The following is a description of a gene set: Genes containing one or more binding sites for (ZNF768) in their promoter regions (TSS -1000,+100 bp) as identified by GTRD version 20.06 ChIP-seq harmonization. from publication Yevshin I, Sharipov R, Kolmykov S, Kondrakhin Y, Kolpakov F (PMID 30445619) Human Gene Set: ZNF768_TARGET_GENES species: Homo sapiens, and this is the list of marker genes: RAP1GAP, REV3L, TXNIP, SSBP1, ZSWIM3, TBC1D22A, PRRG2, RPS27P8, VPS13B, SPAG5, OPA3, RNU5E-4P, ALPL, CEP112 (centrosomal protein 112), CERCAM, MIR4519, SFTA2, KRBA1, OR6S1, MLLT10P2, PVRIG, WDR11, DGAT2, ZNF131, CAP1, ECI2-DT, UBE2Q2P1, SLC8B1, DKFZP434A062, OCIAD1, PPP2R2A, SP110, XYLT1, WSCD1 (WSC domain containing 1), UBE2A, TIGD6, RBPMS2, SELL, MCCC1, SIGLEC14, NSMAF, ATF7IP, IFI16, STMP1, CCDC85C, STIM2, SP140, PLA2G6, ZNF324B, SIRT7, MIR6881, RIPOR2, GDPD5, HOXA11-AS (NCBI Gene Id 221883), CARD10, DOC2GP, TMEM63B, SMPD4, PSMB10, OAS2 (NCBI Gene Id 4939), ELK4, PRR5, ZMPSTE24-DT, KLK10, ETHE1, FZD4 (frizzled class receptor 4), WSCD2, DISP1, TIMM29, RBM47, H2BC16P, SMAGP, CHD1L, SLC1A6, KCNG4 (NCBI Gene Id 93107), RPL5, HS6ST2, F5, ANGPTL6, GTPBP3 (GTP binding protein 3, mitochondrial), FCHO1, CEACAM1, ADGRE1, SYVN1, PLK2, MAP2K6, ROGDI, OTUD3, APOE, COTL1P2, MTR, SEC22C, PHACTR3, SPATA2, SLC25A29, SERPINA1 (serpin family A member 1), CACNA1G, RRAGB, YIPF2, CRYBG2, KHDRBS3, TMEM62, TRAJ35, NRTN, SLC35B1, DUSP10, FOXA3 (forkhead box A3), GZF1, RIPOR3, STARD6, CEBPG, CPNE5, UQCRFS1, TLR4, TRAPPC14, LTBP1, TEX38, LINC01275, RASSF6, MIR4525, PCYT1A, FIBCD1, NDE1P2, OSM, PPIL3, OSGIN1, RNU6-919P, ACOX3, CACNB4, SSB, TAOK3, ARHGAP8, TCL6, SEMA6D (NCBI Gene Id 80031), EXOC3L1, ICAM4, LINC01270 (long intergenic non-protein coding RNA 1270), SH3TC1, RSPO1, CD9, SART1, GRAMD1B, MIR7852, RPL38, LINGO1, NADK, RNF11, CDK5RAP1, SDC3, RPS7, CIAO2A, SAFB, AACS (acetoacetyl-CoA synthetase), CNTN2, PHOSPHO1, PPP1R16B, NIPSNAP1, CASTOR3P, IGKV1OR2-6, SLC35A5, HECW2, ENSG00000273499, ATG14, APOL2, INTS6L, SUGCT, PKM, SNX1, RN7SL399P, ALDH5A1, EML2, RPS18, LSM5, CUTC, MIR4692, UNC119, MFRP, BICDL2, DPY19L2P3, ZNF391, CIT, LINC02447, ZBTB45, SLC6A12 (NCBI Gene Id 6539), CSK, RABGAP1L, PPP1R14B-AS1, B2M, WDR62, RCAN3, DOK7, STRN3, DAAM2-AS1, MED23, CNOT4, RPL23AP89, RNU7-169P, MCOLN1, ACBD6, PXK, KDSR-DT (NCBI Gene Id 118827811), DST, MIPEP, MIR449C, REX1BD, STIM1, H4C16, EIF3G, LY86, LINC01562 (NCBI Gene Id 105378716), ECI2, ITPKC, PDXK, TRPV3, SRC (SRC proto-oncogene, non-receptor tyrosine kinase), ARHGEF1, CD70, PYCR2, FMC1, RNU6-797P, SLC35E2B, CREB5, FBXO21, RBM45, MARK4, UBAC2, MSH4, SYNE3-AS1, NLRC5, CPVL, DLEU2, SCART1, ITGA4, ACACB, IGLV11-55, NCKAP1L, DNAJC25, GPR183, TRMT61A, MYO18A, MAP2K3, FLJ38576, UBAP2L, KCTD10, RN7SL3, CARD8, SS18L2, TMEM242-DT, MIR762HG, POMGNT1, CAMK2B, ODC1-DT, LDAF1, SMIM10L2B, DHRS13, CDH26, SH2D3C, THEMIS2, ITSN1, RERE, S100A13, CCDC33, SULF1, CAND1, MASP1, BTBD6, ENSG00000205890, CEP164, DEPDC5, REPIN1, TMEM40, H4C4, WDR36, PIK3IP1-DT, RGS20, RASSF3, INTS6L-AS1, POFUT1, PDIA5, ANP32A, TRAPPC9, TMEM14B-DT, RN7SL494P, SIAH2 (NCBI Gene Id 6478), SLC29A2, SMCR2, APC, PREPL, TBC1D14, SPINT2, PFAS, DMAC2, ITGB3BP, SLAMF8, EMILIN1, POLG, RN7SKP197, ATOSA, BRF2, DHRS3, ZBTB47-AS1, TUBB8P1, RFTN1, CCDC61, CHST12, PDLIM7, REXO4, RDH10-AS1, SLC23A1, NDUFB4, LONP1, PELATON, KCNH2, PRPF18, ALG10B, TESC, BHLHE23, INTS5, CREM, MTUS2, CCR10, MTHFD2L, ARPIN, KLK15, YJU2B, P2RY8, CASTOR1, TMEM100, ZC3HAV1, SEC14L1, TTC27, PRAMENP, AKT1S1, ZSWIM4, SH3PXD2B, KPNB1, SNORA80D, LINC01596, SLC26A11, ENSG00000230960, SRP72P2, SLA, PRR4, VTRNA1-2, GNG2, TLE5, ZDHHC12, CDC27, PHPT1, LINC02202, TNFAIP8L1, TRIM69, MYO9B, NLRC4, STAP1, NKX2-1, LINC02960, LNPEP, EXOSC3, ATG3, VSTM2L, CFDP1, XXYLT1-AS2, CDK5RAP2, IQSEC1, NAE1, BTG1, SLC44A1, MIR4437, BUD31, SEMA4B (NCBI Gene Id 56962), PAM16, ENSG00000256609, DOCK10, ZNF486, HSPE1P8, LINC02613, ARL11, CCDC25, ITPKB-IT1, KSR1, TMEM87A, ZNF227, ERCC6, DGKE, CASP10, ABCB9, TCIRG1 (NCBI Gene Id 8845), SSBP3, NRN1, MRPL48, CRADD, ADAMTSL5, POLDIP3, BCR, BICDL3P, ELMO1, RNU6-103P, ENPP3, SIGLEC5 (sialic acid binding Ig like lectin 5), CYP3A5, KLHL17, RNU6ATAC32P, PARVG, MARF1, LINC01451, ZNF324, GGT1, TCAP, RRAS2, NTF4, ACLY, FDXACB1, POLRMT, PLEKHA1, COG8, SLC13A3, SDHAF3, DEFB122, TBC1D1, CLIP2, CFL1P1, SORL1, GLCE, CD276, TOB2, LUC7L2, SNX8, AMPD2, C1QTNF6, PITPNC1, PDLIM7-AS1, CAMKMT, RALGDS, UBAC2-AS1, NEMP2, RSL24D1, FXN, WEE2-AS1, PPTC7, SAMD11, DNAJB4, DNMT3B, CD200R1, ASXL1, MAP4K2, KCNQ2, CYP4V2, FUS, PVR, GCKR, TMEM186, NDE1, MILR1, CD19, TTC16, ASAP3, ASPHD2, PRSS47P, TRAPPC13, SULT2B1, PRSS16, MAN2C1, TRIP10 (thyroid hormone receptor interactor 10), TM6SF1, CACNB1, GAR1-DT, RPL37, ARHGAP45, ITPK1, LIMA1, VOPP1, SLC25A43, TAF10, MRPS16, PISRT1, PLCG2, TMEM273, MICAL2, ALDOA, MYO15B, SLC51A, TRIM16, CCP110, NAPEPLD, LIG1, GFI1B, RPL5P24, GANC, KIAA1958, CORO7, TMSB15B-AS1, RNY1, TLE3, ITGA11, LINC02909, PDK1, NDUFB7, UQCC1, STIMATE, TMEM139, JOSD2, NCOA2, DDIAS, PRCP, WDR11-DT, ZNF775, DNAJA2, CYP1A1, IFI6, HAUS8, IGKV3D-20, CLTC, C1orf43, HMGN1, TSPAN16, PITPNB, MPZ, TMC8, SCNN1A, IMPDH2, TRAJ27, TMEM14A, HSD3B7, ADCY7, NUB1, CYSLTR1, KHDC1-AS1, PDK2, ATP8B1-AS1, SFRP5, FAM83G, USP43, GBA1, LINC02185, FBXO17, TMPRSS13, HSBP1, CD180, SMAD7, ARPIN-AP3S2, LINC01095, GIT1, DHX58, NT5DC1, HAUS7, ODAD4, TATDN3, PPP1R1B, HMCN2, RMDN1, UACA (uveal autoantigen with coiled-coil domains and ankyrin repeats), CIITA, CBX8, TMEM44-AS2, SCYL1, TUBA4A, BIK, GYS1, EIF4A3, BPIFB1, TMEM54, ITGA5, TMEM254-AS1, RNU6-532P, E2F2, CACNA1A, IMPDH1, C3, MYRF, KRT15, TRAJ28, BRPF1, CNTNAP1, CILK1, ADGRG1 (adhesion G protein-coupled receptor G1), BOLA1, MT-ND5, CITED1, MIR7973-2, BBX, SCAND1, THUMPD2, MYBL1, MAP4K5, POU2AF1, RGS16, PCLAF, XPO1, OTOF, CCDC6, C1orf167, ZNF611, MIR4531, CDAN1, ROCK1P1, EIF4E2, DMAP1, MRPL34, KRT4, CRYBB2P1, MIR607, H4C8, MGAT3-AS1, PRELP, CTSC, CIB3, EMP1, ARHGAP4, ADD1, PNPLA4, SLC30A6, CPNE9, WHRN (NCBI Gene Id 8016), DHX15, RASAL1, TMED7, RN7SKP91 (NCBI Gene Id 106480861), ITGA3, IPP, CCL22, LINC03048, MIR7973-1, TRMU, IPO9, EAPP, PSENEN, SLC30A6-DT, SMG7-AS1, FABP6-AS1, OTOA, TRIP4, STAB2, KRT7, LINC02136, ATP8B3, MT-TH, DPP4, RPL27, RPL13AP27, SUPT5H, STX6, DRAM2 (DNA damage regulated autophagy modulator 2), LINC00933, SUB1, DEFB124, AKNA, NCF2, JADE2, SCRN1 (NCBI Gene Id 9805), LINC03032, NIBAN3, RN7SL2, PAFAH2, PIGQ, ORC4, COMMD3, EFCAB7, ECE1, TRIM23, MIR5087, ANKRD24 (ankyrin repeat domain 24), EIF1B-AS1, ALDH7A1, MIR3680-1, COMMD7, PAPLN (NCBI Gene Id 89932), NAGLU, PCIF1, KLHL26, TGFB1, PABPC1L, DOHH, CYRIB, STX8, ABCG4, WDFY1, VIPAS39, KANTR, ABHD12, MIR4462, TRMT61A-DT, CYTH4, HK1 (hexokinase 1), TMEM37, SREBF2-AS1, CLIC5 (chloride intracellular channel 5), LBH, NXPH4, CCN5, TCN2, TUSC1, RNU6-560P, SLC38A10, HNF4A-AS1, LINC01685, LINC00881, MB, ZNF581, LINC02977, UBD, DDX3P2, COMMD2, UBR4, ASAH1, LINC01234 (NCBI Gene Id 100507961), SYT12, SGCA, ST3GAL1P1, CES4A, TMED7-TICAM2, GRAMD1A, SYNPO, FCRL5, SUMF1 (NCBI Gene Id 285362), IRAG2, TPI1P2, LRRC27, GIPC2, SMIM9, S100A1, EED, ZNF385A, CSF3R, PHLDB1, CDK11A, HGD, BTBD19, SCNN1D, EXD3, IGSF3, ST6GAL1, RNVU1-2A, LMOD2, ITGAX, PEX5, CD101-AS1, VPS13B-DT, RNU6-244P, CLK3, ST6GALNAC2 (ST6 N-acetylgalactosaminide alpha-2,6-sialyltransferase 2), CCNI2, DNAI4, PNRC2, POLR3E, EIF4E3, C18orf54, VPS52, KPTN, EBF1, PPP1R3B-DT, HIF1A, NR1H2, MAN1C1, ZBTB38, LINC01897, RNVU1-34, CCDC186, RBBP5 (RB binding protein 5, histone lysine methyltransferase complex subunit), MUCL1, CRHR1, MRPL13, ASB2, GRIP2, MAPT-AS1, KRTAP5-AS1, NME1, CNOT6L, ARRDC2, PLXND1, GNAI2, ABCC3, ALDH3B2, UNC13A, FBXO22, CHIT1, GORASP2, EVI5L, ZNF398, STARD10, NASP, MINK1, PTPN14, MIR4521, CIBAR2, P2RY6, JRK, RIN3, DTX4, KLHL20, SYMPK, ADCY6, SLC7A11, LIMCH1 (LIM and calponin homology domains 1), SMAD6, SRCIN1, TTYH3, RPL12P28, MAPT-IT1, LRRC1, UBLCP1, DEPDC1, LINC02356 (NCBI Gene Id 105369984), CLASP1, IRF2BP1, SNX21, MATK, SERTAD2, ZNF473, CNBD2, NOSIP, RBIS, PTPRC, CFAP52 (cilia and flagella associated protein 52), PLEKHA2, FUBP1, NSL1, FOSB, TNRC6B (NCBI Gene Id 23112), PLXDC1, MT-TL2, UTRN, SNX3, TMEM14B, ENTPD4 (ectonucleoside triphosphate diphosphohydrolase 4), POU2F1, DNAJC6, SCARB1, MIR6745, ATAD1, GLIPR1L1, MAP2K4, FOXS1, DAAM1, S100A4, SPACA6, HCG9, CEPT1, U2AF1L4, PI4K2A (phosphatidylinositol 4-kinase type 2 alpha), APBB1IP, RHEX, ANAPC15, VWA8-AS1, TACC2, LGALS12, MIER1, LLGL2, ENSG00000237626, SND1, AURKAIP1, NUP43, SAMSN1, TRIOBP, RAB8A, LINC01852, PRAM1, NT5DC4 (5'-nucleotidase domain containing 4), RHBDF2, GOT2, LINC00926, USHBP1, MCTP1, KCNMB1, MYC, MATN1-AS1 (NCBI Gene Id 100290848), PPP1R14B, SLEAR (NCBI Gene Id 441374), LINC00355, WFIKKN2, LINC01503, ENSG00000238854, NKAIN1, TTF2, LINC03021, UPF3A, CAB39L (calcium binding protein 39 like), ALDH1B1, NAA15, LINC01516, RNU11, GRN, HMGA1, LASP1, DUSP26, SLC2A9-AS1, LINC02703, ZNF74, POC1A, SLC25A42, RBPMS (RNA binding protein, mRNA processing factor), SLC29A4, NDUFC1, ADNP, GATAD2B, ALDH3B1, RBM39, H2BC21, SMCO4, HM13, SALL2, IL4R, MTFP1, CD38, HGS, TREX2, LRP10, RPL37A-DT, TXNRD1, SPC24, STEAP1B-AS1, MFSD5, VPS25, BMPR1B, PCDH9, CTC1, TNFSF18, DPPA2P2, MRPL44, FSCN3, CYTH3, IFI30 (IFI30 lysosomal thiol reductase), PSD4, RNU12, FGFR2, RNU6-1276P, RGS3, MBD4, UBC, HOXA-AS2, CHGA, NEK6, CCDC7, UBP1, MIR1207, CCM2, KRT17P4, PUS10, CAND2, GDF15, HBD, ARHGAP26, IPO9-AS1, GNGT2, PLXNA2, CRACR2A, WNT10A, MAN2A2, SPATA17, TMEM242, BEAN1, RN7SL814P, CD244, LINC01991, PRORSD1P, TESC-AS1, XPO6, SSTR3, MBP, ZNF799, ZDHHC24, DOCK8, LIX1, GTF2H2C, PHF21B (NCBI Gene Id 50609), EMC1-AS1, SLC39A1, FNDC4, MIR6782, KIAA1671, DNAJA3, GCNT2, TIGD1, GSDME, STX5-DT, MYO3B-AS1, TMPRSS6, LRFN1 (leucine rich repeat and fibronectin type III domain containing 1), TJP3, EDN2, ENTPD4-DT, CFAP68, CCDC175, RN7SL36P, PLEKHG1, PLIN5, NEMP2-DT, CFAP298-TCP10L, SNUPN, SSUH2, MCCC2, TXNRD2, MPLKIP, MMP28, AHCYL1, ZNF600, TIMP1, BPESC1, CLSPN, TNNT2, GFAP, PYGM, ARMH1, KMT2D, DLGAP4, PELO, GPATCH2, IGHMBP2, STIM2-AS1, BCL3, STAMBPL1, TRIM31-AS1, IGLV7-46, PRMT1, HTR4 (NCBI Gene Id 3360), TG, PRKCH, PHF19, MRPS31P5 (mitochondrial ribosomal protein S31 pseudogene 5), SETD5, KDM2B, ZDHHC1P1, CFAP298, SEMA3F, ZBTB20, AKTIP, RNU2-63P, TPM4, CLTB, SEPTIN9, MTCO3P12, TYROBP, TTC14, CCR5, MT-TS2, TVP23B, GALNT16, NIF3L1, MOB3A, LINC00620, RNF207, FZD4-DT, ENSG00000259704, LINC01063 (long intergenic non-protein coding RNA 1063), THRAP3, IGLJ5, MIR7106, ZBTB20-AS4, RPL37A, GRHPR, NOXA1, SLC6A6P1, ENSG00000267174, LINC03047, MTUS1, TMED4, PDE4C, PRMT9, KCTD21, BMAL1, SLC2A1, ACTA2, CHRNA7, PHYHIP, HMGN1P36, CDH13-AS2, STAM-DT, PACSIN3, CSNK1E, KLC3, LCN8, LINC02028, ERAL1, LINC00963, PDE2A, ANO1, PLEKHM1, PPA1, IFIH1, B3GNTL1, ZMPSTE24, LDLRAP1, LINC01356, GHRH, NAPSB, APRT, FOSL2, GPHA2, RANBP9, GMFG, MXI1, AK8, LRFN3, DBR1, ARMH3 (armadillo like helical domain containing 3), DLL3 (delta like canonical Notch ligand 3), FAM110A, GIPC1, TMEM254, SH2B1, SLC25A1, PFKFB4, ALKBH2, EIF1B, CYB5R3, CPT1C, DZIP1L, CUZD1, TRAV13-1, SLCO2B1, GHET1, SULT1C2, BCO2, ZNF770 (zinc finger protein 770), TUFM, DACT3-AS1, GPR68, SEC14L2, NAT8B, PLB1, OR4X1, GAR1, NDUFAF1 (NADH:ubiquinone oxidoreductase complex assembly factor 1), VCP, ZNF573, IFIT3, PATL2, TMTC2, OTOG, ESPNP, H2AC16, CEACAM16-AS1, GCA, GRK6, PLXNC1, USP31, CDKN2C, DYSF, RNU5B-1, NOCT, PAQR7, EHMT1, NOX5, CASC11, CLIP4, PLAAT3, RHEB, PCNX2, ZNF749, SLC38A6, CD83, PIP5K1C, PHF14, JDP2, RAB7A, ELF1, TAS2R14, NCOR2, VRK3, NME1-NME2, TGM5, ENSG00000230226, TSC22D4, MPO, NHLRC4, TOR1AIP1, LYSMD2, STEAP3-AS1, CALCRL, CALR, CCNB1, DNM2, THUMPD3-AS1, TINAGL1, FAF1, KCNN3, MIR155HG, DPAGT1, TARS2, OVOL3, TBCEL, LUCAT1, COTL1P1, CLECL1P, LINC02599, YBEY (ybeY metalloendoribonuclease), JPX, ITIH1, CTSS, CXorf58, SNPH, PTS, SIGLEC6, GCC1 (GRIP and coiled-coil domain containing 1), HSD17B2, LINC01271, LINC02332, LCP1, WDR83, SLC12A4, H2AZ2-DT, STN1, COX6B1, MBD5, ACTN3 (NCBI Gene Id 89), RNU6-952P, STK16, PM20D2, OSBPL2, TBC1D10A, SLC2A1-DT, LINC02575, LINC02557, INPP4B, SIRPB2, PRKACB (NCBI Gene Id 5567), EXOC3L4, BCL2L12, APTR, IRX6, IGLV6-57, NUMA1, NECTIN2, DYM, SCD, RPL7L1, HDAC11, SF3B3, MTBP, MFAP5, SGK1, CHRNA3, NR4A1 (nuclear receptor subfamily 4 group A member 1), C1orf52, GLP2R, CREB3L4, ADCYAP1R1, BRF1, GAS8, LINC00511, CATSPERD, GAS7, SPOCD1, ITFG2-AS1, LINC01686, ZNF808, TBC1D23, RSL24D1P11, DRG2 (developmentally regulated GTP binding protein 2), MISP, ETV4, BRD2, STRN, RSBN1L, AHSA1, NEMF, KRTAP4-1, LINGO1-AS2, ZNF341-AS1 (NCBI Gene Id 101929746), ADGRB2, SMG7, CRLF3, IMMP2L, LINC00528, ITGA1, WDR83OS, COX16, SYS1, PRSS53, CD55, C15orf39, MAGI3, ASS1, STAM, IGHA1, CNP, ZC3H12D (NCBI Gene Id 387078), ISG20, PRH1, MCM3AP, CCDC159, ANKRD46, GUSBP1, UBE2F, MAP1LC3B2, DUSP22, MED11, FTH1, ENSG00000226249 (NCBI Gene Id 105378044), TEX19, NR2C2, RIPOR1, FAM222B (family with sequence similarity 222 member B), SLC29A3, ESPN, CCNG1, GVQW3, RN7SL521P, BTG1-DT, MAILR, CSNK1G3, PTPRCAP, MCM5, KANSL3, SLC5A5 (NCBI Gene Id 6528, solute carrier family 5 member 5), ATP6V1G1P5, SRBD1, SF3A3, LRRC37A5P, MAPK4 (NCBI Gene Id 5596), FRA10AC1, RAB5A, PDE8A, NIP7, INPPL1, OPALIN, DNAJC25-GNG10, SERPINH1, TMEM132D-AS1, TCF4, TAF12 (NCBI Gene Id 6883), R3HDM4, GAS2L2, SAMD4A, RHBDD3, TLR1 (NCBI Gene Id 7887), CLEC7A (C-type lectin domain containing 7A), PRKCG, LINC00923, CAPN2, SHANK1, MED26, NEURL1-AS1, TK2, TAF12-DT, KLHDC9, KCNK15-AS1, PDE4D, RUNDC3A, RNU4ATAC, PAK1, CDH16 (cadherin 16), TBX18, ATR, GABARAPL1, DOK4, STARD4-AS1, SNHG5, ADAM19, SLC6A20, RGL3, MTND5P11 (MT-ND5 pseudogene 11), ZNF425, TXNDC12, LITAF, COQ8B, SEMA7A, ACTN4, FIGNL2-DT, OTUD7B, ENSG00000267882, EAF1-AS1, RAPGEF3, EMP2, PIK3IP1